The following is a description of a gene set: Mouse Gene Set: GOBP_ACTIVATION_OF_PROTEIN_KINASE_ACTIVITY Any process that initiates the activity of an inactive protein kinase. species: Mus musculus, and this is the list of marker genes: Ripk3, Tlr1, Prlr, Ins2, Itgb1bp1, Tgfb2, Il4, Ptk2b, Ppia, Ang5, Adcy8, Stk11, Fgf1, Cops8, Tm9sf5, Cab39, Clspn, Tcl1, Lep, Tlr4, Zfp91, Insr, Ntrk3, Ang2, Jak2, Ang4, Sez6l, Ccdc88a, Dlg1, Slc1a1, Gas6, Fbn1, Notch2, Ang, Pibf1, Dynapl1, Strada, Ntf3 (neurotrophin 3), Wnk4, Sez6l2, Chrna7, Wnt5a, Chrna3, Tom1l1, Itgb3, Ppp2r3c, Adra2a, Traf6, Ang6, Abl1, Stradb, Axin1, Nrg1 (neuregulin 1), Adra2b, Prkcd, Angpt1, Igf1, Slc11a1, Dynap, Kif14, Card10, Ins1, Il3, Mt3 (NCBI Gene Id 17751), Sesn2, Adra2c, Pdgfc, Sez6, Chi3l1, Ect2, Tpx2, Emp2